The following is a description of a gene set: species: Mus musculus Mouse Gene Set: GOMF_RNA_NUCLEASE_ACTIVITY Catalysis of the hydrolysis of phosphodiester bonds in chains of RNA., and this is the list of marker genes: Rnase2b, Drosha, Nudt16, Ern2, Rpp25, Ear10, Rnasel, Tsen34, Usb1, Piwil2, Ang, Dis3l2, Elac2, Ago3, Ankzf1, Pnldc1, Polrmt, Slfn1, Slfn2, Nynrin, Apex1, Cpsf3, Pop7, Smg6, Toe1, Tsen2, Ang6, Slfn9, Slfn14, Ear14, Exd2, Nudt16l2, Rnase2a, Rcl1, Mblac1, Exog, Eri3, Zc3h12a, Tmbim6, Nudt16l1, Rnase10, Slfn4, Helz2, Fen1, Nob1, Rpp38, Pop4 (NCBI Gene Id 66161), Xrn1, Rnase1 (NCBI Gene Id 19752), Rnaset2b, Pnpt1, Endog, Lactb2, Rnase6, Slfn8, Snd1, Endou, Rnaseh2a, Xrn2, Slfn3 (NCBI Gene Id 20557), Pan3, Rexo2, Dcp2, Rnaset2a, Ang5, Dis3l, Cwf19l1, Rnh1, Isg20, Cnot6, Khnyn, N4bp1, Pde12, Ago4, Elac1, Ybey, Rnaseh1, Pop1, Mrpl44, Ear2, Prorp, Ago2, Ang2, Dbr1, Ear1, Rida, Marf1 (meiosis regulator and mRNA stability 1), Rnase4, Piwil1, Pld6, Rnase9, Isg20l2, Rnasek, Rpp40, Abce1, Cnot6l, Zc3h12d, Parn, Ang4, Nudt12, Exosc10, Rpp30, Ints11 (integrator complex subunit 11), Zc3h12b, Samhd1, Cnot8, Noct, Ern1, Ear6, Pop5 (processing of precursor 5, ribonuclease P/MRP family (S. cerevisiae)), Myg1, Piwil4, Tsnax, Endov, Eri2, Dicer1, Cnot2, Zc3h12c, Dis3, Rnase11, Eri1, Rnase12, Cnot1, Rpp14, Rnase13, Cnot7, Rpp21, Gm28729, Pan2